The following is a description of a gene set: from publication Chen Y, Wang X (PMID 31504780) Genes predicted to be targets of miRBase v22 microRNA mmu_miR_878_3p in miRDB v6.0 with MirTarget v4 prediction scores > 80 (high confidence targets). studied in species Mus musculus Mouse Gene Set: MIR_878_3P, and this is the list of marker genes: Hecw2, Adam19, Pabpn1, Rnmt, Bmt2, Mbd5, Kras, Cask, Csnk1g3, Tmed10, Eipr1, Btg1, Pigz, Epgn, H2bc4, Acot2, Chd9, Ywhag, Fndc3a, Hikeshi, Bnip2, Rpgrip1l, Tox3, Tlcd4, Eif4a2, Crbn, Cxcl5, Mrpl36, Tshr, Kctd14, Fam98b, Top2b, Bmerb1, Tfrc, Heatr3, Zfp292, Zzz3, Hnf1b, Brinp1, Mylk3, Rnf2, Klf8, Myof, Lifr, Klhl13, Sema3c, Cd53, D630045J12Rik, Bnip3, Zbtb9, Vdac3, Syt16, Vit, Samd4b, Trabd2b, Pex12, Hsd17b7, Sln, Glcci1, Ybx3, Hnrnpd, Wfdc6b, Zfy2, Flg2, Tvp23b, Zswim6, Dram2, Matr3, Wfdc6a, Slc8a1, Srp14, Hsp90b1, Tpt1, Peds1, Ehbp1, Arl8b, Lrrc49, Ppp2cb, Timm9, Krtap3-3, Cops2, Tmed8, Cep128, 2510009E07Rik, Zfp982